Given this list of marker genes PPIA, vpr, vif, gag, rev, vpu, gag-pol, here is a description of the gene set: part of: Reverse Transcription of HIV RNA In the first part of reverse transcription, minus-strand synthesis, a DNA strand complementary to the HIV genomic RNA is synthesized, using the viral RNA as a template and a host cell lysine tRNA molecule as primer. The synthesis proceeds in two discrete steps, separated by a strand transfer event. As minus strand DNA is synthesized, the viral genomic RNA is degraded, also in several discrete steps. Two specific polypurine tracts (PPT sequences) in the viral RNA, one within the pol gene (central or cPPT) and one immediately preceding the U3 sequence (3' PPT) are spared from degradation and serve to prime synthesis of DNA complementary to the minus strand (plus-strand synthesis). During plus-strand synthesis, Preston and colleagues observed secondary sites of plus-strand initiation at low frequency both in the cell-free system and in cultured virus. Both DNA synthesis and RNA degradation activities are catalyzed by the HIV-1 reverse transcriptase (RT) heterodimer. species: Homo sapiens Reactome Pathway: Minus-strand DNA synthesis